Given this list of marker genes BMX, INPP5K, DGKZ, MPDU1, ANAPC2, MEOX2, PRKCB, GIMAP4, RAD50, RTL6, HNRNPR, DYNLT1, LIMCH1, FZD2, PTPRO, LRRC26, SGSH, BCAS3, TSPAN17, PLAGL1, GLCCI1, FIG4, PLVAP, CIRBP, CDC37, CD52, SATB1, CR2, TM4SF1, IRAG2, SORL1, SLC40A1 (solute carrier family 40 member 1), FHL1, PRDM1, ARHGAP1, IFNAR1, IL2RG, GPR182, ST8SIA2, FOXF2, EMC3, GNPDA2, ACOT2, ACYP1, ARAP2, FBXO8, CLBA1, GSTZ1, CCR2, CC2D1A, PDLIM2, LMO2, AGER, ADCY8, RAB31, IRS1, LIMD2, TIPIN, TCTA, PXMP4, TRIM34, GPATCH8, CYTH3, EML3, SRSF5, FKBP1B, SNX2, CNN2, RMND5B, ADGRE5, RAB24, TSPYL4 (TSPY like 4), TSPAN8, MBTD1, BCKDK, HNRNPUL1, MYH7, PBX2, PLEKHB1, LAMA3, CD19, HACL1, PLSCR3, CMTM7, TNFSF10, SLC10A3, LIMS4, HPS3, SORT1, XPA, PACS1, GAB1, MYO1G, SERPINB1, PTPRE (NCBI Gene Id 5791), LYL1, CDKN2C, SRGN, SLC66A2, RPS21, TM2D1, DHX40, FAM107B, EHD2, PGAP4, AKNA, GIMAP1, NEDD4L, DAPK2, APLNR, GASK1B, ARHGDIB, IFNAR2, CCL5, RPS6KA2, MS4A6A, SQOR, SDHAF1, SESN1, POU2F1, GNG11, ARFGAP1, CNR2, IFI27L2, FAM20C, MMP11, PITPNM1, RGS2, HDAC5, EVI2B, ELF5, SLC6A6, HMBOX1, HFE, SLCO2A1, SLC44A2 (NCBI Gene Id 57368), EPS8L2, PTPRC, CD81, SEC31A, BCKDHA, CHST12, CENPB, PLXNC1, ACOT9, APLN, PCCA, ZNF740, CD79B, MAOA, POF1B, ENTPD5, IRF8, CXCR4, MRPS14, TLCD2, PLEKHA1, IFITM3, SLC25A28, ACTR2, FGF18, MSTO1, SP2, TCF3, DECR1, MICAL1, CD79A, ZNF521, COL4A3, WWP2, MYO1C, NMI, NUP210 (NCBI Gene Id 79985), PTPN22, MED12, TBC1D19 (TBC1 domain family member 19), PSTPIP1, ACKR4, MRPS17, ADAMTS5, WNT2, OAZ2, MFAP3, YPEL5, H1-0, CD37, MYLIP (NCBI Gene Id 29116), IK, TACSTD2, HOXB5, SSTR5, ELP1, PTCH1, TMEM131L, CLEC14A, DACT1, LY86, RFX5, SLC7A10 (NCBI Gene Id 83251), ZNF395, here is a description of the gene set: from publication Bauer AK, Rondini EA, Hummel KA, Degraff LM, Walker C, Jedlicka AE, Kleeberger SR (PMID 21543283) species: Homo sapiens We previously identified toll-like receptor 4 (Tlr4) as a candidate gene responsible for ozone (O3)-induced pulmonary hyperpermeability and inflammation. The objective of this study was to determine the mechanism through which TLR4 modulates O3-induced pulmonary responses and to utilize transcriptomics to determine TLR4 effector molecules. C3H/HeJ (HeJ; Tlr4 mutant) and C3H/HeOuJ (OuJ; Tlr4 normal), mice were exposed continuously to 0.3 ppm O3 or filtered air for 6, 24, 48 or 72 hr. Affymetrix Mouse430A_MOE gene arrays were used to analyze lung homogenates from HeJ and OuJ mice followed using a bioinformatic analysis. Inflammation was assessed by bronchoalveolar lavage and molecular analysis by ELISA, immunoblotting, and transcription factor activity. TLR4 signals through both the MYD88-dependent and independent pathways in OuJ mice, which involves MAP kinase activation, NF-kappaB, AP-1, and KC. Microarray analyses identifiedTLR4 responsive genes for strain and time in OuJ versus HeJ mice (p<0.05). One significantly upregulated cluster of genes in OuJ were the heat shock proteins (Hspa1b; Hsp70), Hsp90ab1). Furthermore, O3-induced expression of HSP70 protein was increased in OuJ compared to HeJ mice following 24-48 h O3. Moreover, BAL polymorphonuclear leukocytes (PMN) and total protein were significantly reduced in response to O3 in Hspa1a/Hspa1btm1Dix (Hsp70-/-) compared to Hsp70+/+ mice (p<0.05). TLR4 signaling (MYD88-dependent), ERK1/2, AP-1 activity, and KC protein content were also significantly reduced after O3 exposure in Hsp70-/- compared to Hsp70+/+ mice (p<0.05). These studies suggest that HSP70 is involved in the regulation of O3-induced lung inflammation through the TLR4 pathway and provide evidence that HSP70 is an endogenous in vivo TLR4 ligand. Human Gene Set: GSE20715_0H_VS_48H_OZONE_LUNG_UP Genes up-regulated in comparison of lung tissue from wild type mice subjected to ozone for 0 h versus that from wild type mice subjected to ozone for 48 h.